Given this list of marker genes Pde10a, Thbs1, Nherf4, Pde2a, Pde11a, Mtnr1b, here is a description of the gene set: Mouse Gene Set: GOBP_NEGATIVE_REGULATION_OF_CGMP_MEDIATED_SIGNALING studied in species Mus musculus Any process that decreases the rate, frequency or extent of cGMP-mediated signaling.